The following is a description of a gene set: Intrahepatic biliary atresia studied in species Homo sapiens Atresia in the intrahepatic bile duct. Human Gene Set: HP_INTRAHEPATIC_BILIARY_ATRESIA, and this is the list of marker genes: TMEM67, RPGRIP1L, TCTN3, VPS33B, CLDN1, CC2D2A, INPP5E